The following is a description of a gene set: species: Homo sapiens Human Gene Set: REACTOME_ACETYLCHOLINE_NEUROTRANSMITTER_RELEASE_CYCLE Acetylcholine Neurotransmitter Release Cycle, and this is the list of marker genes: PPFIA1, UNC13B, RAB3A, CHAT, TSPOAP1, VAMP2, CPLX1, STX1A, RIMS1, SLC5A7, SNAP25, PPFIA4, PPFIA3, STXBP1, SLC18A3, PPFIA2, SYT1